The following is a description of a gene set: The process of activating or increasing the rate or extent of mesenchymal cell proliferation. Mesenchymal cells are loosely organized embryonic cells. species: Mus musculus Mouse Gene Set: GOBP_POSITIVE_REGULATION_OF_MESENCHYMAL_CELL_PROLIFERATION, and this is the list of marker genes: Kdr, Shh, Tgfbr2, Ctnnb1, Chrd, Sox9, Six1, Arhgap5, Smo, Irs1, Stat1, Prrx2, Fgfr1, Irs2, Gas1, Prrx1, Fgf9, Hmgb1, Mycn, Bmpr1a, Foxp2, Pdgfa, Tbx1, Wnt5a, Fgfr2, Ihh (Indian hedgehog), Myc, Tbx18, Shox2, Lrp5, Wnt2, Foxp1, Fbxw4, Lrp6, Foxf1